Given this list of marker genes EP300, PATZ1, PDGFB, EWSR1, MN1, CLTCL1, MRTFA, NF2, SEPTIN5, MYH9, BCR, here is a description of the gene set: DNA copy number amplifications activate oncogenes and are hallmarks of nearly all advanced tumors. Amplified genes represent attractive targets for therapy, diagnostics and prognostics. To investigate DNA amplifications in different neoplasms, we performed a bibliomics survey using 838 published chromosomal comparative genomic hybridization studies and collected amplification data at chromosome band resolution from more than 4500 cases. Amplification profiles were determined for 73 distinct neoplasms. Neoplasms were clustered according to the amplification profiles, and frequently amplified chromosomal loci (amplification hot spots) were identified using computational modeling. To investigate the site specificity and mechanisms of gene amplifications, colocalization of amplification hot spots, cancer genes, fragile sites, virus integration sites and gene size cohorts were tested in a statistical framework. Amplification-based clustering demonstrated that cancers with similar etiology, cell-of-origin or topographical location have a tendency to obtain convergent amplification profiles. The identified amplification hot spots were colocalized with the known fragile sites, cancer genes and virus integration sites, but global statistical significance could not be ascertained. Large genes were significantly overrepresented on the fragile sites and the reported amplification hot spots. These findings indicate that amplifications are selected in the cancer tissue environment according to the qualitative traits and localization of cancer genes. Human Gene Set: MYLLYKANGAS_AMPLIFICATION_HOT_SPOT_22 Amplification hot spot 22: colocolized fragile sites and cancer genes in the 22q11.1-q13s region. from publication Myllykangas S, Himberg J, Böhling T, Nagy B, Hollmén J, Knuutila S (PMID 16751803) species: Homo sapiens